The following is a description of a gene set: studied in species Mus musculus Mouse Gene Set: chr15A1, and this is the list of marker genes: Gm24844, Gm2348, Gm16030, Gm10389, Ttc23l, Gm2245, Dnajc21, Oxct1, Gm17873, Gm10250, Gm29742, Gm49249, Pdzd2, Egflam, Selenop, Adamts12, Nup155, Gm5210, C9, Spef2 (sperm flagellar 2), Rictor, Gm8174, Rad1, Gm46497, 1700047G03Rik (RIKEN cDNA 1700047G03 gene), Gm5144, Gm2606, Gm9614, Gm41271, F830212C03Rik, Gm2150, Brix1, C6 (complement component 6), Slc45a2, Gm8139, Gm46496 (predicted gene, 46496), 4930557F08Rik, Gm29753, Rimoc1, Gm5043, Gm8043, Prlr, Ptger4, Mir1898, Slc1a3 (NCBI Gene Id 223326), Gm19276, Gm18715, Gm31282, Lifr, C1qtnf3, Osmr, Fyb1, Snord72, Drosha, Rxfp3, Il7r, Tars1, 4930556M19Rik, Gm2559, 6030458C11Rik, Gm8047, Ghr, Gm34759, Ranbp3l, Capsl, Gm6479, Ccdc152, Gm15937 (predicted gene 15937), Gm16374, Wdr70, Gm24144, Gm2093, Gm17756, Sub1, Gm2310, Gm8238, Gm18714 (predicted gene, 18714), Ugt3a1, Gm7962, Nadk2, Gm7666, Gm2157, Gm15938, C7, Golph3, Gm22031, Agxt2, Gm16311, Gm20957, Gm19227, Gm2573, Rpl19-ps6, Mtmr12, Gm49095, Plcxd3, Dab2, Gm25652, Rai14, Gm5219, Gm4823, Gm2581, Gm41276 (predicted gene, 41276), Gm4940, Prkaa1, Amacr, Card6, Rpl37, Oxct1as, Gm18888, Mroh2b (NCBI Gene Id 74655), Nipbl, Gdnf, Npr3, Gm25550, Skp2, Cdh6, Zfr, Gm16077, Lmbrd2, Ttc33, Fbxo4, Ugt3a2, Cplane1, Gm9630